Given this list of marker genes NRP2, TIFAB, ATP8B1, DCANP1, PAX2, NRP1, NEUROG1, here is a description of the gene set: species: Homo sapiens The process in which the anatomical structure of the vestibulocochlear nerve is generated and organized. This sensory nerve innervates the membranous labyrinth of the inner ear. The vestibular branch innervates the vestibular apparatus that senses head position changes relative to gravity. The auditory branch innervates the cochlear duct, which is connected to the three bony ossicles which transduce sound waves into fluid movement in the cochlea. Human Gene Set: GOBP_VESTIBULOCOCHLEAR_NERVE_MORPHOGENESIS